The following is a description of a gene set: studied in species Mus musculus Mouse Gene Set: GOBP_LONG_CHAIN_FATTY_ACID_TRANSPORT The directed movement of a long-chain fatty acid into, out of or within a cell, or between cells, by means of some agent such as a transporter or pore. A long-chain fatty acid has an aliphatic tail containing 13 to 22 carbons., and this is the list of marker genes: Pla2g2e, Sstr4, Pla2g2a, Pla2g4a, Fabp5, Hrh3, Abcd2, Cpt2, Fabp3, Proca1, Spx, Irs2, Slc27a5, Slc27a4, Oc90, Slc25a20, Lhcgr, Mif, Akt2, Apoe, Cd36, Slc27a2, Eprs1, Ucp2, Abcd3, Fabp9, Pla2g3, Pla2g6, Drd4, Kiss1r, Avpr1b, Cpt1b, Pla2g2d, Plin2, Bdkrb2, Drd3, Drd2, Fabp4, Abcd1, Syk, Pla2r1, Pla2g1b, Acsl1, Mfsd2a, Abcd4, Rps6kb1, Anxa1, Fabp1, Ntsr1, Nmb, Slc2a1, Ace, Abcc1, Atp5pf, Slc27a6, Nmur2, Tmem135, Pla2g2f, Thbs1, Slc27a1, Acsl3, Acsl5, Pla2g2c, Pla2g12b, Pla2g12a, Pla2g4f, Akt1, Hrh2, Fabp2, Pla2g10, Pla2g5, Pparg, Pnpla8, Acsl6